The following is a description of a gene set: Pathway Definition from KEGG: CMG+TRAIP -> CMG == MCM7+Ub -> MCM7+VCP+UFD1+NPL4 species: Homo sapiens TRAIP-dependent replisome disassembly. Pathway ID: N01474. Pathway type: Reference. Pathway class: nt06509 DNA replication. Human Gene Set: KEGG_MEDICUS_REFERENCE_TRAIP_DEPENDENT_REPLISOME_DISASSEMBLY, and this is the list of marker genes: MCM2, GINS1, GINS4, GINS2, UBB, GINS3, MCM3, NPLOC4, CDC45, MCM7, VCP, MCM5, TRAIP, UFD1, MCM6, MCM4